Given this list of marker genes Fgfr2, Pax6, Sox10, Igsf3, Fgf10, Sox9, Foxc1, Muc19, here is a description of the gene set: studied in species Mus musculus Mouse Gene Set: GOBP_LACRIMAL_GLAND_DEVELOPMENT The process whose specific outcome is the progression of the lacrimal gland over time, from its formation to the mature structure. The lacrimal gland produces secretions that lubricate and protect the cornea of the eye.